Given this list of marker genes Mex3c, Tmem135, Slitrk6, Slit2, Rasef, Nuak2, Prrc2c, Dcaf7, Dcp1a, Ptpn3, Ppp6c, Atp2b2, Zbtb44, Ippk, Pth, Ccne1, Nup50, Cdca4, Rnf217 (ring finger protein 217), Ppp1r11, Ano3, Prdm4, Son, Plxna2, Adrb2, Suco, Gpr63, Nrbp1, Ythdc1, Kif5b, Igf2r, Lurap1l, Ube2q1, Helz, Adissp, Dll1, Rreb1, Tll1, Pla2g15, Ret (ret proto-oncogene), Sgk1, Abtb2, Kif1b, Bcl2, Usp42, Kif21a, Mfn2, Stradb, Kpna1, Aar2, Sall4, Prmt6, Ist1 (NCBI Gene Id 71955), Kdsr, Cpeb3 (NCBI Gene Id 208922), Tenm2, Sox6, Rbm6, Mmd, Rictor, Btg2, Ski, Tlk1, Iars1, Ccnjl, Cobll1, Myt1l, Trank1, Atxn2, Ppm1e, Ccnt2, Gpatch8, Chek1, Atp1b4, Chac1, Tacc1, Fam151b, Sesn1, Cdc25a, Usp12, Mgat4a, Luzp1, Tmem178b, Chpt1, Gbp2b, Plekhm3, Cnot6l, Cd2ap, Ezh1, Cbx6, Zbtb34, Anks1, Lrrc32, Mob3b, Bmpr1a, Septin2, Phf19, Akt3, Map2k1, Kl (NCBI Gene Id 16591), Ash1l, Lhx3, Fbln5, Sema6d, Ptprr, Slc6a11, Fgf9, Slc39a10, Rasgef1b, Smad7, Kif1c, Ccr2, Garem1, Usp25, Tmem74b, Scoc, Sec61a1, Rubcnl, Zmym2, Sik1, Prkar2a, Usp15, Islr, Stxbp3, Phc3, Klhl2, Arhgdia, Slc7a2, Rnf10 (NCBI Gene Id 54356), Spryd3, Dync1li2, Phip, Rab11fip1, Kcnj2, Wnt7a, Krtap11-1, Plxnc1, Rere, Man2a2, Ell, Htr4, Trabd2b, Nlrx1, Pou2f1, Atp7a, Lats1, Fgf7, Gm5460, Lrig1, Capns1, Cops7b, Plpp1, Angel1, Ddx3x, Sel1l3, Fbxo21, Rab10, Bicd1, Fermt2, Rfc1, Ccnd2 (cyclin D2), Slc25a22, Sptbn2, Adgrl1, Cmpk1, Cdc37l1, Cert1, Lrp6, Rab9b, Nav1, Pacsin2, Spsb4, Jarid2, Il7r, Pnp2, Ncs1, Wbp11, Cpd, Qki (NCBI Gene Id 66145), Ahcyl2, Cdk12, Wee1, Tnrc6b, Nol4l, Mlycd, Syde2, Grm7, Klc4, Ppp2r1b, Vegfa, Shoc2, Ankrd13b (ankyrin repeat domain 13b), Entpd7 (ectonucleoside triphosphate diphosphohydrolase 7), Wnk3, Klc1, Sema3a, Mapkap1, G0s2, Hapstr1, Eda, Peli3, Spag7 (sperm associated antigen 7), Cdk5r1, Plekhh1, Kbtbd2, Dnajc16, Armcx6, Smurf1, Wipi2, Bcl2l2, Mybl1, Nup210, Ubn2, Tgfbr3, 1700025G04Rik, Pafah1b1, Arih1, Adamts3, Hectd1, Cntnap1, Usp31, Nrn1 (neuritin 1), Idh3a, Atf6, Kcnk10, Zfhx3, Pwwp2b, Phf20, Pam, Usp14, Cpeb2, Fmn2, Sec14l1, Clock, Ghr, Cacul1, Cfap45, Pnpla6, Unc80, Rnf144b, Etnk1, Rfx3, Gm12886, Casr, Polr3f, Dll4, Ubr3, Tuba4a, Higd1a, Ncapg2, Wwp1, Xpo7, Erlin2, Dclk1, Slc4a7, Omg, Tab3, Epha7, Ago4, Fasn, Plcxd2 (NCBI Gene Id 433022), Pip4p1, Seh1l, Nudt7, Atxn7l3, Cdk17, Apln, Traf3, Pdxk, Satb2, Ccdc85b (NCBI Gene Id 240514), Tbpl1, Pnoc, Nfatc3, Desi1, Hmga1, Cacna2d1, Clspn, Trp53inp2, Dixdc1, Kctd8 (potassium channel tetramerisation domain containing 8), Phactr2, Eif3a, Nos1 (nitric oxide synthase 1, neuronal), Col12a1, Akap7, Akap11, Eya1 (EYA transcriptional coactivator and phosphatase 1), Ccdc6, Med26, Slc4a4, Abl2, Acvr2a, Amotl1, Aff4, Cyp26b1, Rad23b, Penk, Fbxw7, Btrc, Capn6, Zfp367, Zfp622, Bace1, Zbtb39, Setd3, Atg14, Nudt4, Selenoi, Slc13a3, Arl2, Raf1, E2f7, Axin2, Zswim3, Zfp449, Srpra, Onecut2, Spred1, Il10ra, Colq, Hephl1, Cpsf7 (cleavage and polyadenylation specific factor 7), Reck, Sall1, Armh4, Zfhx4, Plagl1 (pleiomorphic adenoma gene-like 1), Ywhah, Socs6, Ubfd1, Kif5c, Plxna4, Ube4b (ubiquitination factor E4B), Ago1, Kif23, Slc20a2, Zfp809, Dsel, Pappa, Cbfa2t3, Crebrf, Tbl1xr1, Rarb, Znrf2, Lrig2, Arfgap2, Nufip2, Pappa2, Myb (myeloblastosis oncogene), Chd2, Nectin1, Csrnp1, B4galt1, Itpr1, Zcchc3, Avl9, Actr2, Pip4p2, Med1, Arhgap12, Smim13, Caprin1, Tmcc1, Cc2d1b, E2f3, Dennd10, N4bp1, Wnt3a, Krtap26-1, Sez6l, Crebl2, Pik3r1, Drd1, here is a description of the gene set: from publication Chen Y, Wang X (PMID 31504780) species: Mus musculus Mouse Gene Set: MIR_322_5P Genes predicted to be targets of miRBase v22 microRNA mmu_miR_322_5p in miRDB v6.0 with MirTarget v4 prediction scores > 80 (high confidence targets).